The following is a description of a gene set: Cytokines mediate cell-cell communication in the immune system and represent important therapeutic targets. A myriad of studies have highlighted their central role in immune function, yet we lack a global view of the cellular responses of each immune cell type to each cytokine. To address this gap, the authors created the Immune Dictionary, a compendium of single-cell transcriptomic profiles of more than 17 immune cell types in response to each of 86 cytokines (>1,400 cytokine-cell type combinations) in mouse lymph nodes in vivo. A cytokine-centric view of the dictionary revealed that most cytokines induce highly cell-type-specific responses. For example, the inflammatory cytokine interleukin-1β induces distinct gene programmes in almost every cell type. A cell-type-centric view of the dictionary identified more than 66 cytokine-driven cellular polarization states across immune cell types, including previously uncharacterized states such as an interleukin-18-induced polyfunctional natural killer cell state. studied in species Mus musculus Mouse Gene Set: CUI_MONOCYTE_IL15_RESPONSE_DN Genes negatively differentially expressed in cell type: Monocyte upon treatment with cytokine: IL-15 in mouse lymph nodes in vivo. from publication Cui A, Huang T, Li S, Ma A, Pérez JL, Sander C, Keskin DB, Wu CJ, Fraenkel E, Hacohen N (PMID 38057668), and this is the list of marker genes: Lst1, Fos, Rsrp1, Vgll4, Cx3cr1, Ankrd10, Cd74, Slc46a3, Ifngr1 (NCBI Gene Id 15979), Akip1, Myo1g, Cdc42ep3, Rmnd5a, Actr8, Gpx1, Hspa1a, Ngrn (neugrin, neurite outgrowth associated), Tsc22d3, Mvd, Cspp1, Lrwd1, Cox7a2l, Dusp1, Pdlim2, Adgre4, Zfp36l2, Pou2f2, Btg2, N4bp2l1, Tnfrsf1b, Ormdl3, Meaf6, Map4k2, Jund, Kdm2a, Cebpa, Septin1, Tsc22d4, Klf2, Abi3, Tsc22d1, Cfl2 (cofilin 2, muscle), Eef2, B3gnt8, H2ac24, Prkcd, Otulinl, Ace, Fosb, Tmem176a, Txk, Cd300lb, Sh2d3c, Il16, Madd, Rhob, Phactr4, Sat1, Tnfaip8l2, Tmem176b, Cxcr4, Arl5c, H2-Q6, Uba52, Ankrd44, Tmcc1, Susd3, Ggt5, Mrps27, Ldlrad3, Zfp942, Gpr183, Smim29, Sla, Spn, Rgs2, Eef1a1 (eukaryotic translation elongation factor 1 alpha 1), Calhm2, Ttll4 (NCBI Gene Id 98360), Cd300a, Naca, Ptp4a2, Cbfa2t3, Hpgd, Slc38a2, Klf4, Mbnl1, Tspan32, Nr4a1, Mxi1, Arhgef18, Frmd4b, Ttc17, Gngt2, Pacc1, Arhgap45, Mis12, Abcg1, Hes1, Slc29a1, Cep97, E2f8, Naa80, Arid1a